Given this list of marker genes Uqcrq, Mcl1, Irgm1, Npm3, Ifrd1, Rars1, Capg, Mif, Psmb6, Snhg6, Ddx18, Snx3, Cct8, Cdk6, Timm10, Snu13, Ndufs6, Rsl1d1, Eif2s2 (NCBI Gene Id 99435), Il6ra, Polr1g, Mybbp1a, Twf2, Ndufaf4, Noc2l, Lap3, Eef1e1, Atp5mk, Ppa1, Abhd11, Pebp1, Pa2g4, Aimp2 (aminoacyl tRNA synthetase complex-interacting multifunctional protein 2), Dnajc2, Cenpx, Ndufa12, Lfng, Parp9, Psmb5, Mrto4 (NCBI Gene Id 69902, mRNA turnover 4, ribosome maturation factor), Cdk4, Gadd45gip1, Ddit3, Tbca, Cnbp, Pim1, Sco2, Rrs1, Mbd2, Aen, Polr2h, Pole4, Rexo2, Hnrnpf, Rasgrp1, Glipr2 (GLI pathogenesis-related 2), Nlrc5, Srsf5 (serine and arginine-rich splicing factor 5), Ftl1, Mettl1 (NCBI Gene Id 70215), Dph5, Mrpl23, Cycs, Rrp1b, Cmtm6, Eif1ax, Slc3a2, Tuba1b, Foxn3, Phc3, Snrpa1, Eif4a3, Hsp90aa1, Tnfrsf18, Cyba (NCBI Gene Id 13057), Ssrp1, Rcc2, Aldh18a1, Nifk, Lsm7, Sh3bp5, Mrpl51, Mrpl21, Srsf7, Ms4a4b, Uqcc2, Psma7, Anp32b, Tubb4b, Slfn5, Ndufb6, Eif5a, Nop58, Sec24a, Herpud1, Hspd1, U2af1, Psma2, Stip1, Socs3, Shmt2, Ptges3 (NCBI Gene Id 80424), Xbp1, Surf2, Cndp2, Llph, Igfbp4, Srsf6, Chchd1, Cytip, Gars1, Psmb8, Psph, Isg15, Prpf19, Cyc1, Hspa8, Mthfd2, Srm, Cars1, Pitpna, Sh3bp1, Calm1, Ptma, Ifi35, Bysl, Ipo5, Stat1, Vim, Nars1, G3bp1, Treml2, Eif3b, Timm8a1, Cox6a1, Gpatch4, Eif3a, Atp5f1b, Atp1a1, Ppp1r14b, Ran, Fyn, Ddx39a, Ndufb4, Pfdn2, Tpm3, Atf4, Psme2, Eif4a1, Gnl3, Magoh, Pop5, Tkt, Tomm40, Uchl3 (NCBI Gene Id 50933), Cish (cytokine inducible SH2-containing protein), Hspe1, Timm13, Utp18, Nop56, Fbl, Zfp593, Apex1, Zbp1, Txn2, Grpel1, Mrps18b, Lsm4, Cox5a, Rtp4, Banf1, H2az1, Sars1 (NCBI Gene Id 97063), Rbm17, Gar1, Psmb10, Tcp1, Eif1, C1qbp, Mars1, Mrps15, Cct5, Prpf31, Phgdh, Rrp15, Septin9 (NCBI Gene Id 53860), Nsun2, Gtpbp4, Vars1, Dkc1, Cct3 (chaperonin containing TCP1 subunit 3), Nhp2, Mrpl20, Rrp9, Eprs1, Ifrd2, Cct2, Prmt1, Ncl, Taf10, Tmed5, Nip7 (NIP7, nucleolar pre-rRNA processing protein), Strap, Pfn1, Tars1, Atp5mc1, Mrpl33, Lars1, Srsf2, Rwdd1, Parp14, Ncoa3, Ltb, Rabgap1l, Sdf4, Pcbp1, Fam162a, Iars1, Yars1, Park7, Prdx1, Hspa5, Wdr83os, Snrpb, Xaf1, Arl4c, St13, Socs1, Agpat3, Ddx21, Nolc1, Ruvbl1, Snrpd1, Mrpl15 (mitochondrial ribosomal protein L15), Clic4, Larp1, Aars1, Snrpf, Serbp1, Adh5, Phb1, Ndufb9, Il2ra, Eif2s1, Fkbp4, Eif1a, Ebna1bp2, Cacybp, Il4ra, Mitd1, Ccnd2, Ranbp1, Psat1, Lsm12, Jund, Gpr146, Galk1, Flt3l, Ldha (NCBI Gene Id 16828), Ndufab1, Bst2 (bone marrow stromal cell antigen 2), Cfl1, Ccdc86, Jaml, Set, Ifi47, Osm, Tomm5 (translocase of outer mitochondrial membrane 5), Eno1, Slc7a1, Igtp, Eif3c, Bcl2, Lta, Npm1, Prelid1, Casp8, Nme1, Ecm1, Psmg4, Drap1, Spcs1, Slfn1, Ppan, Myc, Timm9, Ddx39b, Mat2a, Rpf2, Wdr43, Znrd2, Hspa9, Polr2f, Snrpd3, Emc6, Mphosph10, Pum3, Hdgf, Slc25a5, Inpp4b, Aven, Ifit1, Wdr82, Tuba4a, Mrps24, Nudc, Hsp90ab1, Syncrip, Mrpl12, Arid5a, Mrpl30, Rnf213, Impdh2, Mov10, here is a description of the gene set: Genes positively differentially expressed in cell type: CD4+ T cell upon treatment with cytokine: IL-7 in mouse lymph nodes in vivo. Cytokines mediate cell-cell communication in the immune system and represent important therapeutic targets. A myriad of studies have highlighted their central role in immune function, yet we lack a global view of the cellular responses of each immune cell type to each cytokine. To address this gap, the authors created the Immune Dictionary, a compendium of single-cell transcriptomic profiles of more than 17 immune cell types in response to each of 86 cytokines (>1,400 cytokine-cell type combinations) in mouse lymph nodes in vivo. A cytokine-centric view of the dictionary revealed that most cytokines induce highly cell-type-specific responses. For example, the inflammatory cytokine interleukin-1β induces distinct gene programmes in almost every cell type. A cell-type-centric view of the dictionary identified more than 66 cytokine-driven cellular polarization states across immune cell types, including previously uncharacterized states such as an interleukin-18-induced polyfunctional natural killer cell state. Mouse Gene Set: CUI_T_CELL_CD4_IL7_RESPONSE_UP studied in species Mus musculus from publication Cui A, Huang T, Li S, Ma A, Pérez JL, Sander C, Keskin DB, Wu CJ, Fraenkel E, Hacohen N (PMID 38057668)